The following is a description of a gene set: from publication Chen Y, Wang X (PMID 31504780) Mouse Gene Set: MIR_431_5P studied in species Mus musculus Genes predicted to be targets of miRBase v22 microRNA mmu_miR_431_5p in miRDB v6.0 with MirTarget v4 prediction scores > 80 (high confidence targets)., and this is the list of marker genes: Rab5b, Zfp644, Ank, Gm14295, Wdr55, Hipk3, Celsr2, Lamp2, Otud5, Ylpm1, Chodl, D7Ertd443e, Klf15 (NCBI Gene Id 66277), Zfp672, Rasgrp1, Ralgapb, Selenot, Pisd, Zfand2a, Tmem220, Synm, Smurf2, Dicer1, Mapk10, Opn3, Foxj3, Them7, Cnrip1, Daam1, Tmem123, Ube2d1, Gsdma (NCBI Gene Id 57911), Kdm7a, Sec61a2, Pitpna, Taok1, Fndc9, Irf2bp2, Zfp704, Rarb, Casr, Rbpms, Camta1, Mcf2 (mcf.2 transforming sequence), Gpr4